Given this list of marker genes Mtor, Tnf, Rbm10, Mir30a, Inpp5e, Ddx25, Lsm1, Mir125b-1, Apex1, Nat10, Dapl1, Patl1, Bank1, Mirlet7a-2, Rpusd4, Tial1, Sh3bgrl, Rpusd3, Nudt21, Mir133a-1, Mir96, Dap, Hnrnpr, Nlrp5, Eprs1, Dhx9 (NCBI Gene Id 98320), A1cf, Gzmn, Xpo5, Krt13, Msi1, Mirlet7b, Aco1, Ang5 (angiogenin, ribonuclease A family, member 5), Eif2ak1, Sgms1os1, Eif4ebp1, Rbm33, Mir495, Trp53, Endou, Aire, Rock2, Ythdf1, Eif5, Mir196a-1, Caprin1, Tnfrsf1b, Alkbh5, Shmt1, Hnrnpc, Zfp36l1, Uqcc2, Mir668, Mir186, Mir214, Mir129-1, Pelo, Xrn1, Rbm3 (NCBI Gene Id 72067), Zfp598, Hbs1l, Tsc1, Rack1, Mir361, Wtip, Pml, Dcp1b, Sars1, Mir10a, Brf1, Gigyf2, Pnldc1, Plxnb2, Adar, Hnf4aos, Lrpprc, Cdk4, Igf2bp2, Alkbh3, Mir351, Pan2, Ddx3x, Dnajc3, Rcc1l (NCBI Gene Id 94254), Mir448, Mtg2, Mir124-2hg, Mir494, Dkc1, Angel2, Ddx39b, Tarbp2, Cpeb4, Tnrc6b, Tcof1, Prr16, Igf2bp3, Dis3l2, Mir505, Pus7, Ckap5, Mir139, Rgs2, Rida, Elavl1, Aplp1, Igf1, Upf1, Pink1 (PTEN induced putative kinase 1), Padi6, Rbm46, Mirlet7c-1, Traf2, Pum1, Ngrn, Rmnd1, Eif4ebp3, Mir124a-1, Tent2, Traf3ip2, Ncl, Rbm8a, Mir7578, Shfl, Ifrd2, Calcr, Mir125a, Mir466l, Shmt2 (serine hydroxymethyltransferase 2 (mitochondrial)), Ppp1ca, Zcchc4, Tia1, Fech, Fastkd3 (FAST kinase domains 3), Rc3h1, Cyfip1, Eif4a3, Kbtbd8, Fbxo4, Thrap3, Cpeb3, Spout1, Habp4, Abce1, Tnrc6c, Piwil4, Mcts1, Pkp1, Ptbp1, Paip1, Klhl25, Rbms3, Eif2a, Mir3960, Mir135a-1, Trap1, Eif2s1, Ago2, D1Pas1, Nolc1, Tent5c (terminal nucleotidyltransferase 5C), Zc3h18, Mettl3, Eif3k, Fam76b, Mettl14, Fastkd1, Mir100 (microRNA 100), Carlr, Mir875, Pnpt1, Trim71, Malsu1, Rpl38, Zc3h12d, Cnot8, Zfp36l2, Eif4enif1, Mir144, Zc3h10, Sco1, Khsrp, Mir200a, Syncrip, Mir125b-2, Khdrbs1, Rps6kb1, Mvk, Ythdf3, Mir34c, Helz, Neurl1a, Rps9, Mir196b (NCBI Gene Id 723820), Dus3l, Mir26b, Nsun2, Piwil2, Scgb1a1, Casc3, Noct, Mir200b, Gdnf, Focad, Polr2g, Zmpste24, Mov10, Akt1, Per1, Gapdhrt2, Ep300, Mir223, Csde1, Ang, Dicer1, Gspt1, Dxo, Cnot6, Gzmb, Dcps, Hbb-bs, Mov10l1, Il17a, Rps14, Cnot1, Zc3h7a, Rpl5, Tsfm, Mir450b, Eif4a3l2, Eif2b5, Mir196a-2, Arid5a, Mir1247, Epb41l5, Nanos3, Tgfb1, Sesn2, Sarnp, Zc3h7b, Barhl2, Mir7-1, Rxra, Mir137, Eif2ak2, Ptcd3, Mir133a-2, Mael, Ncbp2, Nsun5, Fus, Mtg1, Zc3h14, Ago1, Hnrnpd, Eefsec, Dhx36, C1qbp, Alkbh1, Rps3, Bc1, Ajuba, Mir26a-2, Dgcr8, Ssb, Eif4ebp2, Serbp1, Trmt10c, Il6, Tent4b, Rbm4, Elob, Cnot11, Tent5d, Fmr1, Mir21a, Mir451b, Eif1, Fastk, Pym1, Aars1, Pabpc1, Gzmc, Eloc, Thbs1, Smyd5, Mir129-2, Eef2k, Prkch, Mir182, Mettl18, Ago3, Eif4g1, Rps27l, Mettl8, Mapk3, Gapdhrt, Pcbp1, Tent4a, Mir221, Rps4x, Mir489, Mir9-1, Ace (NCBI Gene Id 11421), Hnrnpa0, Rpl26, Mir124a-1hg, Larp4b (La ribonucleoprotein 4B), Lin28b, Mirlet7g, Zcchc17, Mirlet7a-1, Ptafr, Etf1, Mir26a-1, Dapk3, Mlh1, Coa3, Trub1, Eif4e, Mir155, Ppp1r15b, Slc11a1, Mrpl13, Zfp36l3, Usp16, Abcf1, Lsm14a, Gcnt2, Ucn, Mir23a, Dcp1a, Nrde2, Zcchc13, Prkca (protein kinase C, alpha), Mir451a, Rbm38, Calr, Meioc, Mir107, Sepsecs, Mir7-2, Srsf1, Cdc37, Pcif1, Pcbp4, Tob1 (transducer of ErbB-2.1), Atg14, Rara (retinoic acid receptor, alpha), B3gntl1, Igfbp5, Dcp2, Nanos2, Eif4a3l1, Larp4, Mir34a, Celf2, Ctif, Eif2ak3, Tdrd7, Foxo3, Celf1, Cav1, Rnasel, Plekhn1, Tardbp, Igf2bp1, Map3k20, Trdmt1, Krt17, Eif4g2, Impact, Tut7, Wt1, Trub2, Tsnax, Pcid2, S100a9, Fxr1, Pura, Mir874, Pias4, Upf3b, Mir124a-2, Mir17, Mknk2, Mir154, Ptk2b, Dnd1, Bzw1, Mir33, Tnrc6a, Hnrnpu, Serp1, Piwil1, Rc3h2, Cnot10, Pa2g4, Paip2b, Mir511, Hnf1a, Paip2, Senp1, Pstk, Cpeb1, Eef2, Mir301, Mpv17l2, Poldip3, Tsn, Nmnat2 (nicotinamide nucleotide adenylyltransferase 2), Slfn2, Eif6, Dnajc1, Cnot3, Uhmk1, Prmt1, Mir101a, Pde12, Mex3d, Akt2, Parp16, App, Prg3, Zswim8, Lin28a, Samd4, Ikbke, Mirlet7e, Cacng7, Gemin5, Upf3a, Fto, Jmjd4, Cnot2 (NCBI Gene Id 97648), Eif4g3, Mirlet7c-2, Vim (vimentin), Gcn1, Mapkapk2, Mir203, Itga2, Zfp706, Ncbp1, Pabpn1l (poly(A)binding protein nuclear 1-like), Unk, Phax, Bcl3, Zar1, Nck1, Mecp2, Gtsf1, Naf1 (nuclear assembly factor 1 ribonucleoprotein), Xbp1 (X-box binding protein 1), Vegfa, Ybx2, Cpeb2, Rbm4b, Secisbp2, Ythdf2, Mir504, Clp1, Rpl13a, Mir124a-3, Npm1, Dhx29, Tirap, Gapdh-ps15, Erbb2, Mir423, Rpl10-ps3, Gtdc1, Tyms, Carhsp1, Helz2, Tent5a, Ngdn, Pan3, Mrps27, Boll, Eif4e3, Eif3e, Mir143, Cdk5rap1, Tbrg4, Tent5b, Rbm47, Guf1, Cirbp, Lsm14b, Pabpc4, Otud6b, Cyp1b1, Btg2, Cnot9 (NCBI Gene Id 98400), Dazl, Ogt, Dapk1, Elavl4, Pld1, Ago4, Slc35a4, Msi2 (musashi RNA-binding protein 2), Sox4, Ppp1r15a, Akap6, Tex19.1, Caprin2, Pkm, Bcdin3d, Eif5a, Cnot7, Cnbp, Larp1, Limd1, Eif2ak4, Parp9, Mapkapk5, Adad1, Mir183, Eif5b, Rps6kb2, Ripk1, Bzw2, Prkdc, Apobec1 (apolipoprotein B mRNA editing enzyme, catalytic polypeptide 1), Ogfod1, Mapk1, Matr3, Srp9, Eif3d (eukaryotic translation initiation factor 3, subunit D), Enc1, Rbm24, Larp6, Mir21c, Magoh, Ddx6, Tmed2, Zar1l, Rpl10, Zfp385a, Bmp4, Gapdh, Zfp36, Mir7b, Ilf3, Rnf139, Ythdc1, Myd88, Vip, Taf15, Fastkd2, Trnau1ap, Wfs1, Mettl5, Fxr2, Patl2, Ern1, Mir1a-2, Mir7116 (NCBI Gene Id 102465671), Mir21b, Nsun3, Csdc2, Eif4e2, Tpr, Mettl1, Taco1, Mir153, Qki, Tut4, Ybx1, Rock1, Ddx49, Nck2, Stat3, Nicol1, Eif3b, Samd4b, Axin2, Mir101b, Ireb2, Nanos1, Mir146, Pum2, Scrib, Rplp1, Grb7, Niban1, Ncbp3 (NCBI Gene Id 97706), Traf5, Mir873a, Parn, Mettl16, Nsun4, Mknk1, Mir1a-1, Pum3, Fastkd5, Mif4gd, Cnot6l, Eif5a2, E2f1, Mir205, Mir324, Zc3h12a, here is a description of the gene set: Mouse Gene Set: GOBP_POST_TRANSCRIPTIONAL_REGULATION_OF_GENE_EXPRESSION Any process that modulates the frequency, rate or extent of gene expression after the production of an RNA transcript. species: Mus musculus